Given this list of marker genes Rhag, Kcnk1, Kcnk6, Kcnk9, Kcnk7, Kcnk10, Kcnk18, Nalcn, Kcnk16, Kcnk3, Kcnk15, Kcnk2, Tmem175, Kcnk12, Kcnk5, Panx1, Kcnk4, Kcnk13 (potassium channel, subfamily K, member 13), here is a description of the gene set: Mouse Gene Set: GOMF_NARROW_PORE_CHANNEL_ACTIVITY Enables the transport of a solute across a membrane via a narrow pore channel that may be gated or ungated. species: Mus musculus